Given this list of marker genes Plcl2, Ccl19-ps6, Cx3cl1, Casq1, Hap1, Plcg1, Cxcr3, Txn1, Arl2, Ubash3b, Nr5a1, Taf3, Cxcl10, Trpc1, Akap6, Asph, Mprip, Park7 (Parkinson disease (autosomal recessive, early onset) 7), Sorl1, Fbn2, Ccl21f, Insig1, Pgr, Ccdc88a, Chrd, Kdelr2 (KDEL (Lys-Asp-Glu-Leu) endoplasmic reticulum protein retention receptor 2), Hspa5, Uvrag, Plch1, Gaa, Tmem38a, Anxa6, Fam76b (NCBI Gene Id 97522), Hrc, Grk2, Ghitm, Ptk2b, Ngf, Tmem38b, Slc8b1, Spout1, Adcy6, Sun1 (NCBI Gene Id 77053), Sp100, Mdfi, Ciz1, Trdn, Xcr1, Gper1, E230001N04Rik, Drd1, Gp1ba, Ccl19-ps1, Htr2b, Coro1a, Plcb4, Pkd2, Camk2d, Ms4a2, Lgals1, Pink1, Nol3, Cav1, Selenon, Aspm, Gstm7, Cherp, Ank3, Ank2, Aplnr, Tnrc6a, Ccr5, Epg5, Nrros, Gsto1, Plce1 (NCBI Gene Id 74055), Cxcl11, Sirt1, Cacna1c, F2, Flna (NCBI Gene Id 245705), Skp1, Vps13c, Nbl1, Tpcn2, Ccl19-ps5, Gp5, Cd19, Jph2, Npsr1, Fgf2, Akap9, Htt, Pkp2, Srgn, Psen1, Gpr39, Akt1, Itpr1, Myo5a, Topors, Lck, Kdelr3, Dand5, Gp9, Jsrp1, Ccl21d, Pln, Ccl3, Plcl1, Ptpn6, Fasl (Fas ligand), Dmd, Insig2, Lime1, Mtln (NCBI Gene Id 67885), Dhrs7c, Apoe, Sufu, Fkrp, Cacna1s, Lgals9, Xcl1, Cxcl9, Vps13d, Atp7b, Tmem232, Plcg2, Itpr2, Plcb2, Htr2a, Arhgap21, Capn3, Ryr2, Jph3, Cd4 (NCBI Gene Id 212762), Cyba, Cdk5 (NCBI Gene Id 12568), Itpr3, Pml (promyelocytic leukemia), Casq2, Ccl19, Cemip, Mcoln1, P2rx7, Lyn, Prkce, Calm1, Rer1, Prkd1, Tmed2, Sri, F2r, Bax, Cer1, Ptprc, Syne1, Vps13a, Slc25a23, Taf8, Trpm2, Bdkrb1, Tacc3, Mfsd8 (NCBI Gene Id 99720), Tgfb2, Supt7l, Fkbp1b, Arl2bp, Ankrd13c, Pde4d, Lgals3, Ccl21e, Fkbp1a (FK506 binding protein 1a), Tbccd1, Hnrnpu, Os9, Golph3, Ednra (endothelin receptor type A), Itgb3, Bard1, Letm1, Gpsm2, Kdelr1, Glp1r, Polr2m, Mettl21c, Dbi, Pex5l, Gja1, P2ry6, Diaph1, Il13, Ryr3, Atp2a1, Clec4b1, Pafah1b1, Igsf11, Gp1bb, Sppl2c, Ccl19-ps3, Itgav, Hk1, Morc3, Htr2c, Slc8a1, Rangap1, Hk2, Chd7, Bbs4, Fcrl5, Plcb1, Calm2, Thy1, Ccl21a, Fbn1, Ibtk, Ero1a, Tspo, Hdac3, Frey1, Ryr1, Tgfb1, Ccl19-ps4, Grik5, Lhcgr, Drd2, Ddit3, F2rl3, Snca, Abl1, Sun2, Ltbp1, Dbn1, Ccl21b, Plch2, Ntsr1, Rit2, Calm3, Pdpk1, Plcb3, Atg5, here is a description of the gene set: Any process in which a cell, substance or cellular entity, such as a protein complex or organelle, is maintained in a location and prevented from moving elsewhere. Mouse Gene Set: GOBP_MAINTENANCE_OF_LOCATION studied in species Mus musculus